Given this list of marker genes ENPP1, IGF2, FBP1, ARPP19, PDK3, P2RY1, OGT, IER3, PSEN1, FLCN, GCGR, PPP2CA, PRXL2C, LHCGR, HTR2A, MTCH2, POMC, TCF7L2, AP2A1, PPARGC1A, ACACB, PPP1R3A (protein phosphatase 1 regulatory subunit 3A), PDK2, RORC, NCOR1 (NCBI Gene Id 9611), PPP4R3B, IRS2, IGFBP3, PDK4, SIRT1, LEPR, FOXK1, UCHL1, NNMT, LCMT1, PPP1R3G, PTH1R, MIR195, GPD1, DGAT2, TREX1, RANBP2, WDR5, PPP4R3A, PTH, GNB3, SIK1, ZBTB7A, TRIM63, PMAIP1, SELENOS, ALDOB, AKT1, ZFP92, INS, SESN2, USP7, ZNF692, STAT3, MIR103A1, CRY1, MIDN, ARNT, PRKAG1, ERFE, PPP1R3C, SLC35B4, C1QTNF12, MLXIPL, TP53, MIR107, MIR15B (microRNA 15b, NCBI Gene Id 406949), PHKA1, NR0B1, PRKAA1, EIF6, GCG, ADIPOR1, SMPD3, SLC4A4, MST1, GSK3B, AKT2, GNMT, GPER1, PRKACA, PPP1R3D, DDIT4, SORBS1, SIRT6, NFE2L1, ADIPOQ, C1QTNF1, CLK2, SRC, PRKG1, RUBCNL, NCOA2, ACTN3, CBFA2T3, PFKFB1, PHKG2, ZMPSTE24, AVPR1B, GRB10, PPARA, JMJD8, MIR1271, SIRT7, PPP1CA, MTOR, IGF1, PPP1R3F, IFNG, KHK, PLEK, PRKAG2, NR3C1, APP, ARL2, RORA, TGFB1, HDAC4, GPLD1, FOXO1, NUPR1, MTCL2, NFKB1, IGFBP4, FOXK2, PASK, SLC45A3, P2RY6, ADCY10, SCARB2 (NCBI Gene Id 950), GCK, MLST8, MIR210, NTSR1, NLN, DYRK2, SLC2A6, INPP5K, GIT1, MLYCD, HMGB1, ACADM, PPP1R3B, SNCA, EP300, EGF, TFF3, DGKQ, SLC4A1, GCKR, CLTC, ADCYAP1R1, GAPDHS, PGP, HAS2, KAT2B, CD244, P2RX7, INSR, GSK3A, PTPN2, PRKAG3, HIF1A, PRKN, PRKAA2, KAT2A, LEP, DDB1, SDHAF3, PPP1R3E, PDGFB, ZBTB20, RPTOR, SERPINA12, C1QTNF3, BCKDK, PHLDA2, EPM2AIP1, PDK1 (NCBI Gene Id 5163), TIGAR, IRS1, here is a description of the gene set: Human Gene Set: GOBP_REGULATION_OF_CARBOHYDRATE_METABOLIC_PROCESS Any process that modulates the frequency, rate or extent of the chemical reactions and pathways involving carbohydrates. species: Homo sapiens